Given this list of marker genes Timp1, Apela, Fbn2, Smurf2, Ago2, Arhgdib, Acvr1c, Syde1, Nodal, Vegfa, Mmp12, Calr, Ythdf3, C1qbp, Gja1, Itgb3, Acvr1b, here is a description of the gene set: Any process that modulates the frequency, rate or extent of trophoblast cell migration. species: Mus musculus Mouse Gene Set: GOBP_REGULATION_OF_TROPHOBLAST_CELL_MIGRATION